The following is a description of a gene set: Genes down-regulated in AGS cells (gastric adenocarcinoma): control versus H. pylori LPS. This study set out to identify global changes in gene expression in AGS gastric epithelial cells following 8 hours stimulation with 10 μg/ml lipopolysaccharide (LPS) from the gastric pathogen H. pylori. Microarray analysis was used to compare changes in gene expression between cells treated with 10 μg/ml H. pylori LPS and untreated cells at the same time point. from publication Smith SM, Moran AP, Duggan SP, Ahmed SE, Mohamed AS, Windle HJ, O'Neill LA, Kelleher DP (PMID 21220698) species: Homo sapiens Human Gene Set: GSE25146_UNSTIM_VS_HELIOBACTER_PYLORI_LPS_STIM_AGS_CELL_DN, and this is the list of marker genes: ING4, IVNS1ABP, ATXN7, PRPF38B, ASH1L, DENND1C (NCBI Gene Id 79958), OGT, PPP3R1, ZC3H14, CSNK1A1, LAX1, NEMP2, TBC1D2B, ITSN2, CASD1, SFT2D1, PHF21A, SEMA7A, VWA5A, TPR, RBM39 (NCBI Gene Id 9584), ZFC3H1, STK39, TRAPPC14, GRAP2, PIN4, TNRC6A, RUNDC3B, BOD1L1, CLK4, FOSB, VPS36, CMAHP, TAF4, MYB, SAMD3 (sterile alpha motif domain containing 3), PDK1, MED8 (NCBI Gene Id 115853), RANBP6, TRIM68, CXCR5, MX1, IDE, SRSF6, LGALS8, HNRNPH1, CEP95, SLC20A1, TIA1, MTA3, NR4A1, DOCK9, TRAF1, ENTPD4 (ectonucleoside triphosphate diphosphohydrolase 4), CTLA4, MOB3A, DICER1, RASA1, ARID4B, TENT5C, CCNL1, THAP12, TMEM62, MARCHF7, CTSE, EPS8L1, XRN2, ZNRF1, JCHAIN, EEA1, SRSF2, GBP5, CDK11B, NIPBL, HNRNPR (heterogeneous nuclear ribonucleoprotein R), SRSF7, MYCBP2, CCNT2, SLC1A5, SHOC2, CCNL2, DOCK10, SNAPC4 (NCBI Gene Id 80189), SLC16A5, EXOSC2, BDP1, JAK1, CDR2, RPS6KB1, COG3, ZC3HAV1, PRP4K, SESN3, GPR132, PDE4D, RGS1, DDX17, NAMPT, BCLAF1, SETBP1, PRMT7, GBP4, TTC14, SIRT7, NCLN, DDX3X, PIK3C2A, ARHGAP9, FBXL20, CEBPZ, DHX36, XAF1, NKTR, TMEM254-AS1, SENP5 (SUMO specific peptidase 5), ZKSCAN3, PPIL4, LILRB4, TMEM87B, ZC3H7A, PPP4R3A, ENTPD1 (NCBI Gene Id 953), STX4, KTN1, MALT1, USP33, DUSP6, FAM120A, GEMIN5, CCL3, MRPS21, NFKB2, GNL2, MBNL1, AFF4, L3MBTL3, CLCN7, PRRC2C, FRG1, ITGB2, CD69, STAT1, KCNN4, RELB, ZRSR2, EML4, DDX5, NLRC5, PPCDC, PDE2A, ZFAND2A, PNISR (NCBI Gene Id 84956), EXOC1, TUG1, CCNT1, MAPK8IP3, ZBTB41, ERBIN, MYC, GBP6, CNTRL, SRSF10, TOMM70, MPHOSPH10, PKNOX1, PLCB2